Given this list of marker genes LMBRD2, CHD8, HDAC8, GATA6 (GATA binding protein 6), PEX11B, GATA4, TWIST1, ESCO2, PEX6, PEX12, OPHN1, SHANK3, ERCC4, NSUN2, GJA5, TAF1, UBE2A, PEX19, BRAF, FHL1 (NCBI Gene Id 2273), HBA1, FBXO31, EDA (ectodysplasin A), CAV1, SOX11, PRR12, PHF6 (PHD finger protein 6), FLNA (filamin A), RAB23, IDS, SIK3, NKX2-5, GDF1, PDGFRB, ANTXR1, KCNJ8, ARX, GHR, JARID2, GPR101, FBXL4, PIK3R1, BSCL2, CRELD1, PIK3CD, JAG1 (jagged canonical Notch ligand 1), PTCH1, FGFR3, SUZ12, ZIC1, TRAPPC9, MAP2K1, MASP1, RBMX, FLT4, COL11A2, LZTR1, SOST, TBX1, PPARG, AP1G1, PEX1, MEGF8, SLC25A24, HBA2, FOS, PEX14, PEX3, FGFR2, MAP3K7, PPP1R21 (NCBI Gene Id 129285), PIGA, SP7, WDR26, TOE1, ABCC9, SEC23A, PITX2, PAK3, PHF8, PEX26, PTH1R, PEX2, POLR3A, PEX5, KIF11, PRMT7, ZSWIM6 (zinc finger SWIM-type containing 6), ZFPM2, AIP (aryl hydrocarbon receptor interacting protein), SPOP, FREM1, PSMC3, CITED2, SKIC3, MAP2K2, LIG4, FGFR1 (fibroblast growth factor receptor 1), DRG1, KRAS, LBR, KDR, GRIA3, RPS6KA3, PEX13, PEX10, CAVIN1, PEX16, CTCF, KNSTRN, NEU1, NKX2-6, LAS1L, RBM10, MYOD1, TCF12, AGPAT2, GATA5, here is a description of the gene set: An anomaly of the supraorbital portion of the frontal bones. Human Gene Set: HP_ABNORMALITY_OF_THE_SUPRAORBITAL_RIDGES studied in species Homo sapiens Abnormality of the supraorbital ridges